The following is a description of a gene set: Mouse Gene Set: MIR_6355 from publication Chen Y, Wang X (PMID 31504780) studied in species Mus musculus Genes predicted to be targets of miRBase v22 microRNA mmu_miR_6355 in miRDB v6.0 with MirTarget v4 prediction scores > 80 (high confidence targets)., and this is the list of marker genes: Ttc28, Abcd3, Nfyb, Ptbp3, Gpm6a, Mab21l2, Eif5a2, Wnk1, Chd1, Chl1, Sim1, Dnaja2, Pdhx, Ppp1r8, Slc25a16, Cpsf7, Igf2r, Upf3b, Pafah1b2 (platelet-activating factor acetylhydrolase, isoform 1b, subunit 2), Bclaf1, Tle4, Zfp991, Mdga2, Hoxd8, Crebrf, Nelfa, Satb2, Tns1, 1700031F05Rik, Grm5 (glutamate receptor, metabotropic 5), Tmem165, Arhgef7, Uevld, Mbnl1, Ssx2ip, Kitl, Mynn, Ccnt2, Taf1b, Kpna3, Pign, Vezf1, AI182371, Napg, Ahcyl2, Mbtd1, Rab4b, Zfp9, Phip, Angpt1, Rimbp2, Hif1a, Ppp2r5c, Foxg1, Nr1d2, Kcna1, Hps3, Ubr7 (ubiquitin protein ligase E3 component n-recognin 7 (putative)), Eny2, Tbx18, Epha4, Fos (NCBI Gene Id 14281), Pes1 (pescadillo ribosomal biogenesis factor 1), Naa15, Usf3, Zfp987, Tcf12, Papolg, Fyn, Slc7a11, Mybl1, Tcim, Sp1, Etl4, Zbtb18, Ppargc1a, Zfp985, Kif18a, Luc7l3, Phc3, Osbpl3, Pdk4, Klf6 (Kruppel-like transcription factor 6), Etv5, Esyt2, Terb1, Lin7a, Appl1, Brpf1, Txndc16, Gtf2e1, Dyrk1a, Xrn1, Rev3l, Pik3r1, Zfp984, Inip, Pak3, Lsm11, Dnaaf11, Ctnnd2, Zfp704, Hipk3, Enpp1, Nap1l2, Tbl1xr1, Acot5, Rap1b, Nedd1, Hnrnpc, Zfp268, Nampt, Cstf2t, Smg1, Kmt2e, Plekhf2, Ptbp2, Dll4, Smim15, Ift140, Atxn1l, Rcor1 (NCBI Gene Id 28079), Irgm2, Gnpnat1, Srpk2, Akap17b, E2f6, Mtss1, Pde4b, Pkhd1, Wdr44, Fndc3b, Cnot2, Zfp992, Fem1c, Klhl14, Pdcd6ip, Kcnma1, Ptprz1, Tex11